The following is a description of a gene set: studied in species Homo sapiens Human Gene Set: GOBP_LUNG_ALVEOLUS_DEVELOPMENT The process whose specific outcome is the progression of the alveolus over time, from its formation to the mature structure. The alveolus is a sac for holding air in the lungs; formed by the terminal dilation of air passageways., and this is the list of marker genes: GATA6, LTBP3, MYOCD, ATXN1L (ataxin 1 like), FOSL2, SELENON, ERRFI1, TCF21, IGF1, KDR (kinase insert domain receptor), MMP12, ITGB6, TGFB3, HOXA5, ATP7A, ASXL1, SMPD3, ABCA12, PDGFA, NKIRAS1, HS6ST1, COL6A1, PHF14, LIF, SLC7A11, BMPR2, PGR, CLDN18 (claudin 18), ATXN1, SFTPD, FOXP2, CIC (capicua transcriptional repressor), FOXF1, FGFR2, TGFB1, FOXA1, CREB1, EDN2, PKDCC, MAN1A2, IGFBP5, STRA6, ADA (adenosine deaminase), MAN2A1, HOPX, NKX2-1, BLOC1S6, FGF10, RC3H2, BMP4, TMEM38B, STK40, FBN1, NKIRAS2 (NFKB inhibitor interacting Ras like 2), FLT4